The following is a description of a gene set: studied in species Homo sapiens Reactome Pathway: PTK6 Regulates RHO GTPases, RAS GTPase and MAP kinases PTK6 promotes cell motility and migration by regulating the activity of RHO GTPases RAC1 and RHOA. PTK6 inhibits RAS GTPase activating protein RASA1 and may be involved in MAPK7 (ERK5) activation part of: Signaling by PTK6, and this is the list of marker genes: RAC1, DOCK1, CRK, ELMO2, RASA1 (NCBI Gene Id 5921), ELMO1, KRAS, NRAS, ARHGAP35, HRAS, PXN, BCAR1, PTK6, RHOA